The following is a description of a gene set: from publication Chen Y, Wang X (PMID 31504780) Genes predicted to be targets of miRBase v22 microRNA hsa-miR-1224-5p in miRDB v6.0 with MirTarget v4 prediction scores > 80 (high confidence targets). species: Homo sapiens Human Gene Set: MIR1224_5P, and this is the list of marker genes: FMNL3, ZNF418, KLHL4, ANTXR1, ANKIB1, TNS1, ZNF208, RANBP10, FAM78B, TMEM175, KRT73, UBAP2L, MS4A6E, FHIP2A, CPA6, ARHGEF19, KRIT1, PFKFB2, ZNF384, REDIC1 (NCBI Gene Id 283461), GTDC1, CNGB3, RPE, KITLG, GABARAPL2, PCMT1, SPATA31F3, MADD, NIPA2, COQ4, HNRNPU, BCAT1, ZNF257, PTGR3, TMEM221, ZDHHC15, ZNF676, ZNF716, GALNT2, PRSS16, MSI2, HBP1, CEP120, NEBL, CCDC186, MDH1B, LBP, S100A12, ZNF664, PPP1R9B, PRRX1, TSPAN5, SEPTIN11, XRCC5, SV2A, ZNF99, KIAA1549L, ZDHHC6, OGFOD1, CXCL6, TROAP, FCRL5, FNDC3B